Given this list of marker genes SLC26A2, MED25, TBX2, COL1A1, PLOD3, NEDD4L (NCBI Gene Id 93998), SMC1A, here is a description of the gene set: Human Gene Set: HP_JOINT_CONTRACTURE_OF_THE_3RD_FINGER Joint contracture of the 3rd finger Chronic loss of joint motion in the 3rd finger due to structural changes in non-bony tissue. The term camptodactyly of the 3rd finger is used if the distal and/or proximal interphalangeal joints are affected. studied in species Homo sapiens